The following is a description of a gene set: studied in species Mus musculus Reactome Pathway: TRP channels part of: Stimuli-sensing channels electronically inferred by orthology from the curated human pathway This event has been computationally inferred from an event that has been demonstrated in another species.<p>The inference is based on the homology mapping from PANTHER. Briefly, reactions for which all involved PhysicalEntities (in input, output and catalyst) have a mapped orthologue/paralogue (for complexes at least 75% of components must have a mapping) are inferred to the other species., and this is the list of marker genes: Trpc5, Trpv5, Trpc4ap, Trpm4, Mcoln1, Trpc6, Trpc7, Mlkl, Trpm5, Trpc1, Trpv2, Trpv6, Trpm8, Trpm6, Trpa1